Given this list of marker genes Xdh, Tymp, Icmt, Nmnat2, Dpyd, Ada, Nt5e, Pcmt1, Macrod1, Pnp, Nt5c2, Mtap, Dctd, Adal, Nmrk1 (NCBI Gene Id 225994), Pycr3, Urad, Cda, Slc25a51, Nt5c1a, Ptgdr, Pgm2, Pnp2, Upp2 (NCBI Gene Id 98890), Nmrk2, Adk, Dera, Tk1, Nudt1, Enpp4, Acp3 (NCBI Gene Id 77915), Pemt, Dnph1, Upb1, Nt5c3, Uox, Cdadc1, Ak1 (NCBI Gene Id 59018), Ahcy, Tk2, Dtymk, Aprt, Gnmt, Upp1, Hprt1, Qng1, Gamt, Aicda, Urah, Dguok, Dck, Bloc1s6, Ahcyl, Nt5c1b, Oard1, Gda, Macrod2, here is a description of the gene set: species: Mus musculus The chemical reactions and pathways involving a nucleoside, a nucleobase linked to either beta-D-ribofuranose (a ribonucleoside) or 2-deoxy-beta-D-ribofuranose, (a deoxyribonucleoside), e.g. adenosine, guanosine, inosine, cytidine, uridine and deoxyadenosine, deoxyguanosine, deoxycytidine and thymidine (= deoxythymidine). Mouse Gene Set: GOBP_NUCLEOSIDE_METABOLIC_PROCESS